The following is a description of a gene set: Human Gene Set: GOBP_LEUKOCYTE_MEDIATED_IMMUNITY studied in species Homo sapiens Any process involved in the carrying out of an immune response by a leukocyte., and this is the list of marker genes: VAV1, GATA3, NCR3, CD27, IL9, IL6, CLNK, IL12A, IGHG1, MASP2, SCIMP, PLEKHM2, IFNA2, C8A, GPR15LG, MAPK3, FZD5, ITGAM, KLRC3, BCL6, C1RL, CD160 (CD160 molecule), IGHV1-69, JAG1, UFL1, GAB2 (NCBI Gene Id 9846), C1QB, NOD2, RAB27A, CLEC2A, TYROBP, FBXO38, IGHV4-4, IGHV3-73, HPX, CEBPG, IRAK4, CLEC4G, ULBP1 (NCBI Gene Id 80329), HLA-G, PIK3R6, C4B, IGLC3, C4A, CD19, IL9R, PMS2, KLRC4-KLRK1 (KLRC4-KLRK1 readthrough), STAT5A, FCGR3B, KIR2DL4, PLA2G1B, CTSH, CLCF1, C7, TNFSF13, MSH6, IFNB1, IL18RAP, IGHE, CD96, PTPRC, IL23A, PLA2G3, TNF, IL4, ERCC1, FCER2, SLAMF7, TNFRSF1B, TBX21, AHR, IGHV4-59, C1QC, FERRY3, GZMM, TREM1, KLRF2, PIK3CB, PLCG2, GFUS, KMT2E, CD8A, SNX4, IGHV3-16, ANXA3, CD274, CEACAM1 (CEA cell adhesion molecule 1), EXO1, MR1, IGHV1-24, BST2, IGHG4, BCL3, CD226, HLA-F, LILRB1, IGHV3-11, IGHV3-64, IGHV2-70 (NCBI Gene Id 649805), MAVS, IGHV5-10-1, AICDA, IGHV3-53, FCAR, IGKC, NFKBIZ, IGHV3-21, CCR6, DNASE1L3, CD70, C4BPA, SLA2, IGHV3-48, AIRE, SNAP23, USP5 (ubiquitin specific peptidase 5), VAMP2, C2, NECTIN2, LAT, RNF19B, CCL3, IGHV3-15, IGHV3-72, VAMP3, EXOSC3, SERPINB9, KLHL22, MAD2L2, LGALS9, TREX1, GRP, GZMB, BCL10, IGHV8-51-1, HPRT1, FCGR1BP, KLRC1, PTPN6, SPHK2, CALHM6, CXCL6, CD55, IL20RB, ADAM17, TLR4, ADGRE2, DHX36, CR1, SASH3, TUBB4B, NKG7, TICAM1, SLAMF6, TRAF2, NCKAP1L, C8B, DNASE1, F2RL1, NOS2, CD1B, TUBB, GNL1 (G protein nucleolar 1 (putative)), KIT, PDPK1, KLRC4, CD28 (CD28 molecule), STXBP3, KLRD1, BTK, ELANE, C1S, KIF5B, RASGRP1, LTA, BTN3A2, IGHA2, CD1C, NDST2, HLA-DRA, MSH2, IGHV4-34, ZP3, PRAM1, SANBR, NBN, TLR3, GATA1, SHLD3, IL10, FCGR2C, IGHV3-13, ATAD5, IL7R, LYST, SNX6, C9, DBH, KLRB1, SCNN1B, WDR1, RAET1E, IGLL5, SCN11A, TFRC, EMP2, MALT1, IL13, IGHV3-66, ARRB2 (arrestin beta 2), CARD9, ICAM1, PIK3R1, TP53BP1, APLF, IRF7, IGHV4-61, TAP2, DAO, INPP5D, IGHV4-39, FCGR2A, C1QBP, IGHV3-49, IL4R, FOXP3, CTSG, GRB2, CD1A, CLEC12B, IGHV3-64D, SUPT6H, C1R, IL13RA2, HSPD1, MYO1G, UNC13D, CX3CR1, FOXJ1, CLC, STAP1, IGLC7, FGR, KIR3DL1, SPON2, IGHV3-35, RIPK3, IGHV3-43, LIG4, CYRIB, ARID5A, C3, CRK, IGHV1-18, BATF, RIGI, HCST, IL6R, IL2, CD1E, ARL8B, LILRB4 (leukocyte immunoglobulin like receptor B4), CTSC, TLR8, IGHV1-69D, BCR, KLRC2 (killer cell lectin like receptor C2), HLA-H, SHLD1, CRTAM, RAET1L, IGHV5-51, RAET1G, IL23R (NCBI Gene Id 94006), RASGRP4, KMT5B, CSF2RB, RFTN1, JAGN1, HLA-A, TRAF6, STX4, EBAG9, LEP, DDX21, IL1B, HMCES, MAP3K7, SH2D1A, PRDX1, IGHV3-38, FCGR3A, TIGIT, FOXF1, NLRP6, CORO1A, PRF1, CCR2, IL12RB1, SCART1, PIK3CD, CFI, PTGDS, IGHV1-58, IGHG3, ADORA2B, CR2, NSD2, FCRLB, C5, BTN3A3, IL4I1, IGHV7-81, IGHV4-31, CD80, CADM1, NCR1, CD46, HLA-DRB1, IGHV7-4-1, SECTM1, SERPINB4, ULBP3, IGHV6-1, IGHV3-33, IGHV3-74, AGER, IGHV3-7, JAK3, RNF8, SHLD2, EXOSC6, DDX1, PRKCD, ACE, STAT5B, HLA-C, PIK3CG, HMGB1, FCMR, YWHAG, KMT5C, IL18 (interleukin 18), NR4A3, RABGEF1, MRGPRX2, XCL1 (X-C motif chemokine ligand 1), TNFSF4, SLAMF1, IGHV4-28, HLA-B, IL2RB, IGHA1, LAMP1, NCF1, PVR, MYD88, IGLC2, ITGB2, CAMK4, CLEC7A, LYN, IGLL1, CD40LG, SLC22A13, MILR1, CD40, SERPING1, S100A13, FADD, STXBP2, IL12B, RAB44, DENND1B, TRPM4, PRKAA1, SYK, LAG3, B2M, C6, FUT7, TUSC2, CD7, ULBP2 (UL16 binding protein 2), SLC18A2, TREM2, CD2, SLC15A4, CLU, RIF1, TGFB1, CD74, NLRP3, FCGR1A, IGHV3-30, SUSD4, SPI1, PAXIP1, PTGDR, KDM5D, STAT6, VAMP8, SMAD7, HLA-E, TCIRG1, IGHV2-5, STXBP1, IGHV3-20, CBL, KLRK1 (NCBI Gene Id 22914), CHGA, CD81, CD177, RAC2, IGHV1-3 (immunoglobulin heavy variable 1-3), RNF168 (NCBI Gene Id 165918), GATA2, POMC, IGHD, PCYT1A, IGHV3-23, IGHG2, CD300A, CR1L, VAMP7, MICA, TRAF3IP2, NECTIN4, PRKCZ, P2RX7, CD84, AZU1, IL1R1, STX7, HLA-DRB3, PCYOX1L (prenylcysteine oxidase 1 like), C8G, MBL2, CD1D, ZBTB1, FCER1A, AZGP1, SWAP70, C17orf99, PDCD1, WAS, SPN, HFE, PARP3, CPLX2, C4BPB, MLH1, IGHV1-69-2, IL21, PPP3CB, IGHV2-26, DUSP22, SH2D1B (SH2 domain containing 1B), IL27RA, HAVCR2, FCER1G, IGHV2-70D, IGLC1, FES, UNC93B1, NDFIP1, RSAD2, AP1G1, LAT2 (NCBI Gene Id 7462), C1QA, F2, IGLC6, TLR9, ARG1, UNG, FCGR2B, IL18R1, IGHV1-45